Given this list of marker genes Cfh, Cfhr1, Vsig4, Itgam, Cr1l, Itgb2, Cfhr4, Phb1, Cfhr2, here is a description of the gene set: studied in species Mus musculus Mouse Gene Set: GOMF_COMPLEMENT_COMPONENT_C3B_BINDING Binding to a C3b product of the complement cascade.